The following is a description of a gene set: species: Homo sapiens Human Gene Set: GOBP_IMMUNOLOGICAL_SYNAPSE_FORMATION The formation of an area of close contact between a lymphocyte (T-, B-, or natural killer cell) and a target cell through the clustering of particular signaling and adhesion molecules and their associated membrane rafts on both the lymphocyte and target cell, which facilitates activation of the lymphocyte, transfer of membrane from the target cell to the lymphocyte, and in some situations killing of the target cell through release of secretory granules and/or death-pathway ligand-receptor interaction., and this is the list of marker genes: EPHB1, PRF1, DOCK8, NCK2, CD6, CCL19, GIT1, DOCK2, CORO1A, NEDD9, CCL21, CCR7, CD81, HAVCR2, LGALS3, MSN, CD2AP, DLG1